The following is a description of a gene set: studied in species Homo sapiens Human Gene Set: MODULE_39 Genes in the cancer module 39., and this is the list of marker genes: AP3S1, ARCN1, HPCA, SEC24D, HPCAL1, AP2S1, LRP8, AP2A1, AP1S2, SEC31A